The following is a description of a gene set: Mouse Gene Set: chr9A2 studied in species Mus musculus, and this is the list of marker genes: Gm19178, Or7g12, Or7g20, Gm23048, Gm34263, Or7g17, Cwc15, Deup1, 4930540M03Rik, Gm7680, Gm24455, Or7g22, Or7g27, Vstm5, Mif-ps6, Naalad2, Gm48849 (predicted gene, 48849), Med17, Or7g18, Mbd3l2, Gm5119, Or7g32, Mre11a, Mir7650, Or7s1a-ps1, Gm2594, Fut4, Gm10706, Chordc1, Gm22579, Gm34973, Ubtfl1, 1700012B09Rik, Slc36a4, Gm48856, Mbd3l1, Or7g21, Gm24299, Or7g26, Zfp558, Hephl1, Fat3, Gm7642, Gm15586, Or7g16, Gm7751, Kdm4dl, Gm18997, Gm5612, Taf1d, Or7g25, Gm7692, Mtnr1b, Or7g19, Gm4977, Amotl1, Gm19174, Gm19790, Gm22658, Or7f1-ps1, Or7n1-ps1, Panx1, Smco4, Cep295, Muc16, Piwil4, Or7s1-ps1, Gm18789, 4931406C07Rik, Gm23455, Scarna9 (NCBI Gene Id 100216535), Gm24339, Kdm4d, Or1m1, Ankrd49, Or7g23 (NCBI Gene Id 258184), Gm22620, Gm7607, Izumo1r (NCBI Gene Id 97560), Or7g28, Gm24357, Gm24546, Or7g31, Or7g29, Gm2517, Or7g30, Gm25791, Gm48634, 4930584E12Rik, Or7g24-ps1, Gpr83, Gm5611